Given this list of marker genes Ercc3, Gtf2h2, Taf6, Tbp, Ercc2, Polr2i, Gtf2f2, Polr2f, Taf7, Taf8, Gtf2h4, Taf15, Taf13, Taf11, Taf5, Gtf2e1, Polr2k, Taf1, Polr2l, Taf9b, Polr2c, Taf4b, Polr2b, Taf7l, Gtf2f1, Taf12, Ccnh, Gtf2e2, Gtf2a1, Polr2e, Gtf2b, Polr2a, Taf10, here is a description of the gene set: Reactome Pathway: RNA Polymerase II Transcription Initiation And Promoter Clearance part of: RNA Polymerase II Transcription electronically inferred by orthology from the curated human pathway studied in species Mus musculus This event has been computationally inferred from an event that has been demonstrated in another species.<p>The inference is based on the homology mapping from PANTHER. Briefly, reactions for which all involved PhysicalEntities (in input, output and catalyst) have a mapped orthologue/paralogue (for complexes at least 75% of components must have a mapping) are inferred to the other species.